The following is a description of a gene set: Mouse Gene Set: GOBP_REGULATION_OF_LYMPHOCYTE_CHEMOTAXIS studied in species Mus musculus Any process that modulates the frequency, rate or extent of lymphocyte chemotaxis., and this is the list of marker genes: Cxcl13, Stk39, Klrk1, Adam17, Ccl3, Wnt5a (wingless-type MMTV integration site family, member 5A), Ccr2, Wnk1, Cxcl14, Adam10, Slc8b1, Padi2, Ccl21a, Nedd9, BC037156, Oxsr1, Tmem102, Xcl1 (chemokine (C motif) ligand 1), Ccr7, Ptk2b, Tnfsf14, Ccl7, Lgals9, Ccl12, Ccl5, Cxcl10, Il4